The following is a description of a gene set: from publication Lopez-Serra L, Ballestar E, Ropero S, Setien F, Billard LM, Fraga MF, Lopez-Nieva P, Alaminos M, Guerrero D, Dante R, Esteller M (PMID 18223687) species: Homo sapiens Human Gene Set: LOPEZ_MBD_TARGETS Genes up-regulated in HeLa cells (cervical cancer) after simultaneus knockdown of all three MBD (methyl-CpG binding domain) proteins MeCP2, MBD1 and MBD2 by RNAi. Methyl-cytosine-phosphate-guanine (CpG)-binding domain (MBD) proteins are bound to hypermethylated promoter CpG islands of tumor suppressor genes in human cancer cells, although a direct causal relationship at the genome-wide level between MBD presence and gene silencing remains to be demonstrated. To this end, we have inhibited the expression of MBD proteins in HeLa cells by short hairpin RNAs; and studied the functional consequences of MBD depletion using microarray-based expression analysis in conjunction with extensive bisulfite genomic sequencing and chromatin immunoprecipitation. The removal of MBDs results in a release of gene silencing associated with a loss of MBD occupancy in 5'-CpG islands without any change in the DNA methylation pattern. Our results unveil new targets for epigenetic inactivation mediated by MBDs in transformed cells, such as the cell adhesion protein gamma-parvin and the fibroblast growth factor 19, where we also demonstrate their bona fide tumor suppressor features. Our data support a fundamental role for MBD proteins in the direct maintenance of transcriptional repression of tumor suppressors and identify new candidate genes for epigenetic disruption in cancer cells., and this is the list of marker genes: CCNI, SPINT2, TMEM258, ELK3, SEC16A, C5, NPEPL1, ANXA4, LRPAP1, ELAC1 (NCBI Gene Id 55520), PSME2, ATF1, MAPK10, FAM89B (NCBI Gene Id 23625), DNAJC8, TUBB2B, MMP2, UPP1, SLTM, RPL24, ATG7, PSMB10, KDM1A, FTSJ1, EIF2A, CSF3R, INPP5B (NCBI Gene Id 3633), APH1A, BUB1, EBNA1BP2, RUVBL1, MINK1, ARMCX4, ZBTB8OS, FAM3A, ANXA1, CAPZB, RPS24, TCEA1, KIAA2013, GDI2, HMGN4, CTSC, TFAM, KPNB1, FANCA, FBXO34, RALGDS, CDC34, KRT5, ALDH9A1, EVPL, ATP6V0C, PMM1, SERPINA1, GAL, ALAS1, IPPK (NCBI Gene Id 79194), NSUN3, MAP3K10, EIF1, CDH5, NSA2, TLE6, LITAF, PRELID1, STAP2, ACTR3B, MYBL2, EIF4B, MRPL15, PHB1, TMEM248, PRDM2, HNRNPF, IFI6, NPPB, CDC42, DLK1, FDXR, CDH16, ITGA5, HDGF, RRM2 (ribonucleotide reductase regulatory subunit M2), PPIB, SORBS1, DFFA, NAP1L1, TXNRD1, IL27RA, TBC1D25, RPS7, C5orf15, RANGAP1, GNB1, PAXX, FNDC3A, SEPTIN7, ZNF75D, LDHA, BIRC5, TENT4A, IPO7, HSPG2, ANXA11, LYZ, EDC4, MBTPS1, SSNA1, POLE4, SGCB, AK4P3, FNTB, ROMO1, MT2A, TRAP1 (NCBI Gene Id 51721), PCBP2, ASF1B, ATP5MK, TSPAN3, RHEB, NR2F6, POGLUT3, PRKXP1, PARVG, ST6GALNAC5, NAALADL1, EIF3H, TCOF1, WDR18, CCT5, NCAM1, ERRFI1, PICALM, PPHLN1, FBXO4, RAB1A, VIL1, CTPS1, ADSL, SMAD5, KIF11, RHOB, DECR2, AHCY, TP53I3, SMCO4, IL13, HNRNPH2, TRRAP, EWSR1, PTPRN, NKG7, RBM5, RPLP0, HSPA8, TUBB3, HTR6, PAXIP1, EIF2S1, MEG3, AGO1, PPP2R5D, ARHGEF2, SH2B1, CYP21A2 (cytochrome P450 family 21 subfamily A member 2), ST13, TXN2, NCF1, BMP4, IFITM2, DCTN6, FN1, RSPRY1, GARS1, SECTM1, RAB8A, CTSH, NEK7, NDUFS3, BAZ2B, HSPA1L, TGFB1I1, PSMB9, WARS1, ZBTB25, CDK5, CRAT, CD53, SNCG, CNTN2, PMPCA, YBX3 (NCBI Gene Id 8531), COMMD6, CAPN5, SERINC2, GADD45B, EEF2, RNPEP, TSPAN32, NDUFAB1, ADD3, C7, FBXW2, RSAD1, AKT1S1, HUWE1, PRKCSH, SNX1, DDX21, ZNHIT2, CYFIP2, MCM3, COX20, PPP1R10, SELENOP, SEC61A1, UQCR11, SNAP47, ALDH3B1, TOP2B, XRCC1, TP53BP2, MALT1, DSC2 (NCBI Gene Id 1824), RAB6A, BEX3 (brain expressed X-linked 3), PPIF, OBP2B, ACTN1 (actinin alpha 1), FGF19, UBE2A, EIF3E (eukaryotic translation initiation factor 3 subunit E), SLC15A3 (NCBI Gene Id 51296), LFNG, PCDHB2, SEMA4D, PRDX1, RAF1, RPN1, ENTR1, GPC3, CCL19, TMEM234, CROCCP2, APLP2, BRAF, EIF2S2, MUL1, UBE2I, AP3S1, ITGA11, AMBRA1, TERT, SIKE1, KRT7, GLRX, EIF3K, NFKBIL1, PKM, S100A10, NUMA1, USP5, KIAA0319L, GHITM, TRAF5, PAICS, DDX3X, RNF113A, FUBP1, FGF11, GSTM3, EIF4A1, VHL, RAB2A, CCT6P1 (NCBI Gene Id 643253), CDK5RAP3, PCMT1, MAT1A, EEF1D, ERLIN1 (NCBI Gene Id 10613), SUB1, TPM3, TNFSF11, DNAJC4, EPS15L1, CRIM1, SYT12, CYCS, EIF3J, LINC00484, KDELR1, TMEM50A, FKBP8, RAP1B, DLD (NCBI Gene Id 2654), PDHA1, WDR82, APLN, POLRMT, TSC22D1, EIF4G3, TKFC, SPP1, RPL31P7, CDK20, P2RY6, PSMA5, TUBBP5, ACTN4, YES1, SPIDR, GOLGA6L9, UCK2, CFL1, TUSC3, MAST2, THRA, CREBBP, ZBTB46, FDX1, PSMA4, AKAP9, ALDOA, FNTA, RPL37, RNPEPL1, FAM107A, WNT5B, BLVRB, ENG, BTG3, CISD1, MEAF6, SHOX2, NEAT1, NAXD, ZNF496, KRT17, SUPT5H, ABHD2, FABP1, MIDEAS, ILF2, CPSF7, AP4M1, LGMN, GABBR2, GNS, CCL26 (C-C motif chemokine ligand 26), NUBP2, NFKBIA, ITM2B, PFKM, TCIRG1, CNTNAP1, INSIG1, TPT1, SRA1, IDH3G, SLC43A3, DAZAP2, CLCF1, PPP1CC, AREG, CX3CR1, TSSC4, MYC, CD27, FBXO42, GNAZ, ZNF79, CAPN12, SDC4, TOMM7, NPC2, USP20, BTG1, NME3, BTF3 (NCBI Gene Id 689), CDKN1A, DDB1, PSME3, APP, HNRNPL, ATP5MC2, CDC37, SERPING1, RAB9A, LRP5, EIF3I, CDK2AP2, CUL4A, FLI1, SERPINA5, ZFP91, COL11A2, MXD4, RPS27L, TG, PKN3, AIF1L, PTPRF, DISP3, C1QC, ENO1, FGFR3, H1-2, SLC45A1, ADIPOR2, FAH (NCBI Gene Id 2184), RRAS2, PTH1R, PPIH, MTCL2 (NCBI Gene Id 90072), CTBP2, PROCR, MAP2K5, CCDC6, BCL7B, DUSP3, PPP1R13B, CHMP4A, TARBP1, UBE2B, CKB, CCS, SKP2, HES2, TBCA, MORN1, RCE1, PFDN6, SFN, PCDH12, CRADD, PSMD9, SSU72, SLC29A2, URM1, SERPINH1, RAP1A, CHMP1A, IGFBP2, HYAL1, MAT2A, TUBA3C, PFN1, ANXA7, RPL31, ITGA2, AGPAT3, LTF, MAG, RHOA, CTTN, EZR, CYP2A6, NHERF1, DOK4, CYB561A3, CELA2A, IARS1, SPTAN1, PIEZO1, TUBG1, CD63, UBA1 (ubiquitin like modifier activating enzyme 1), TOP2A, EOLA2, TGIF1, CNKSR1, XPO7, PSMB3, FASTK, ENTREP3, SPARC, RABGGTA, DDT, RPAIN, MED22, GGTLC2, RXRA, ERG, QKI, SIVA1, LTBR, EIF1AX, SERPINE1, GOT1, ADCY7, RAN, H2AC7, DNPH1, DOT1L, PCNA, ZNF592, POLR2H, TPRG1L, RRM1, DUT, RBX1, HOXC4, GRK5, CCDC22, SUPT6H, ARPC3, FOXK2, SPIN1, OXA1L, ACTN2, HMGN2, HLA-F, MAZ, POLR2F, PUF60, LAPTM4A, SF3A1, PPP1CA, IMPDH1, CARHSP1 (calcium regulated heat stable protein 1), ATP6V0B, CSF1R, COL8A2, MAP3K11, DRAP1, COL4A2, RPS19, MRFAP1, STARD4, LYPLA1, TUBA1A, PSMD8, USP22, MED27, DNAI1, TBCD, MUTYH, AXL, CYP51A1, NOSIP, GAS7, PAX8, PSMC2, MCTS1, MAL, BNIP3L, ALPL, ACSS2, PITPNM1, ATP5F1C, NDUFS8, ATRAID, PSMB4, CREG1, PPP2CB, CRY1, FIP1L1, MYL11, PPP2R1A, MAX, CAPN1, PDCD5, RNF121, PCID2, RPL11, RPS8, TUBA4A (tubulin alpha 4a), ERAP1, PHF19, IRAK1, MTM1, BPGM, ATP1B2, SRSF4, UBA52, EIF6, YWHAE, XRCC5, GLO1, SCARB2, SLC2A9, OVOL1, CCT4, RPL10A, BIRC3, ATG9B, CDK11A (NCBI Gene Id 986), IL1R1, TGFB2 (transforming growth factor beta 2), EIF3CL, ATP6V1F, CDKN1C, C1orf174, ACTR1A, HPRT1, PPP1R12B, LTBP3, F8A1, YY1AP1, FUT11, RPS14, RAB37, CEBPA (CCAAT enhancer binding protein alpha), FBXO2, RAD50, ATP6V1G1, GANAB, TGS1, MRRF, RBM7, RPS6KB2, HDHD2, IL10RB, CCDC88C, KMT2A, EPHA1, AGPAT2, MMP1, ITGB7 (integrin subunit beta 7), LRRFIP1, PPIL2, SREBF2, DGCR6L (NCBI Gene Id 89178), CTDSPL, ACTA1, COPB2, ACTR1B, MED13, ADA, PPA2, NUDCD3, PTTG1, SELPLG, WWC1, VPS8, ABCB6, HSBP1, RPS21, NDUFV2, PLA2G15, SLC43A1, FOXN3, PRDX2, KPNA1 (karyopherin subunit alpha 1), IFITM1, SAAL1, CCNB2, PSMA2, NSMCE1, PSMA1, PTGES3, GJB3 (NCBI Gene Id 91028), KRTAP5-9, CCN1, PDK2, GLE1, SON, MFNG, CCT3, JUNB, RIPK2, SHC1, PSMB7, DPH7, EPAS1, AATK, MRPS27, BMP1, ARPC4, FANCC, MEN1, TOMM40, PSMC4, THBD, MTG2, RBBP4, ABCC2, SERPINA6, STK40, CNBP, FAM241B, UBAC1, MAGEA8, PTTG1IP, LRRC41, NSF, PPP1CB (NCBI Gene Id 5500), CDK1, SSBP3, CETN2, E2F4, WIPF1, POLD4, PPIE, IFI30, ENKD1, THOC2, ADGRE3, PSMC3, RHOC, ARL2, NDUFV1, SEMA3C, NRG2, SNRPF, NQO2, ATP5MF, RAD54L, XPA, ALDH5A1, PTP4A1, TFDP1 (transcription factor Dp-1), CD70, VTN, SVEP1, SMARCD1, STK4, C15orf39, STIP1, VWA1, ARHGDIA, OTUB1, RAB10, ANO6, RPL18, IFITM3, MFAP1, SLC19A1, MRTO4 (MRT4 homolog, ribosome maturation factor), ROR2, YWHAQ, WDR89, CLUH, ARID4B, NDUFC1, MUS81, STMN1, CPT2, PVALB, DNAAF5 (dynein axonemal assembly factor 5), SEC61B, GNAQ (NCBI Gene Id 2776), PATL1, CD99L2, DHRS11, RIN1, SP1, RING1, RPS6KA1, GTF3C4, GABARAP, RFC3 (replication factor C subunit 3), SDC3, MEI1, BCAS2, SPRR2G, ZNF692, MED16 (NCBI Gene Id 10025), IFRD1, MIER1, GAS8, SEMA4C, PPP3CA, SERF1A, TRAPPC9, VRK1, PPP6C, RAD51, DTYMK (deoxythymidylate kinase), AZGP1P2, NBPF1, PDCD10, NUDT1, CATSPERZ, ENO3, FCN1, SPCS1, HDAC11, MAP4K2, NUCB2, UBE2D2, ATF4, SIGLEC7, SLC35B1, PLSCR3, FBXO7, SPRR2C, ENOX2, CYTL1, PSMD12, TXNDC17, POU2F2, FAM110D, TM7SF2, CLEC2B, SMARCD3, CDK2, IRX4 (NCBI Gene Id 50805), RYR1, ECH1, MLLT3, HLA-E, OSTC, MED7, SMARCC2, DAZAP1, RARA, PLAAT3, CDK16, CHD5, SLC22A18, KCTD20, UGT3A1, PA2G4, UBXN11, IGF1R, PPP1R15B, FGFR1, FES, TH, KRT14, BTBD19, MMRN2, ANAPC15, CYP8B1, MEA1, MFSD12, EHD2, POU5F1, PTPRU, ALDOB, RAB31, THAP8, RRP12, ESRRA, C2CD2 (C2 calcium dependent domain containing 2), PRKCG, FGFR4, ARMCX2, CASP2, GSTP1, BTF3L4, NKIRAS2, NPDC1, MT1X (NCBI Gene Id 82523), RPS2, CORO1A, EPO, BRINP1, MYCBP2, EPHB4, PTPN11, PPP3CC, CORO2A, CTSK, PLPP2, RPL36AL, ELF4, ACADVL, SRGN, RPL35A, EVL, ITPRID2, HDAC5 (NCBI Gene Id 23342), DMAP1, STAR (NCBI Gene Id 6770), HMGB1, MICALL2, FAM234A, RACK1, COMMD1, UPF1, WDR45, METTL23, ILF3, GUSB, HLA-B, NCOA4, APLP1, MOK, ABCD1, CGB3, DDX23, COX8A, GNG10, HCLS1, CDH15, FOLR1, SLC2A8, CSE1L, ITIH3, CISD3 (CDGSH iron sulfur domain 3), SFXN4, CDC42EP1, CA9, TMEM53, IRAK3, ECM1, DHFR, UBE2C, TNC, HSPB1P2, DYNC1I2, PPIC, ZNF518A, RAB3A, CTNNB1, LHB, UBE2D3, RAB5C, NECAB3, NDUFB3, MSH2, TFG, ZNF320, PNPO, ANXA5, QSOX1, UBTD2, APRT, CLPB, USP9Y, UBE2S, AIP, STAT5A, SOD1, VCL, TPD52L2, GHDC, SLC2A1, UIMC1, ARL6IP4, RGS3, SLC12A4, SGK1, NUDT21, HNMT, APEX1, POLR1D, SET, RABIF, COQ4, PXDN, NDUFB7, NR4A1, UBE2M, PACS1, FGG, ZNF43, ATP6V0D1, MAPK3, ABCC5